Given this list of marker genes TERT, PRIM2, PPP6C, RFC4, TERF1, SHQ1, DKC1, POLD2, NOP10, LIG1, PRIM1 (NCBI Gene Id 5557), WRAP53, POLD4, RPA3, POT1, STN1, RPA2, RFC2, CCNA1, CDK2, RFC5, POLD1, ACD, PIF1, RFC1, BLM, TEN1 (NCBI Gene Id 100134934, TEN1 subunit of CST complex), PPP6R3, TINF2, CHTF18, WRN, ANKRD28, RTEL1, TERF2, TERF2IP, RUVBL2, FEN1, PCNA, NHP2 (NCBI Gene Id 55651), RFC3, RPA1, POLD3, GAR1, DNA2, POLA2, DSCC1, RUVBL1, CCNA2, POLA1, CHTF8, CTC1, here is a description of the gene set: Extension of Telomeres studied in species Homo sapiens Human Gene Set: REACTOME_EXTENSION_OF_TELOMERES